Given this list of marker genes CDC20B, CDC20, PLK1, FZR1, CDK2, here is a description of the gene set: Any process that modulates the frequency, rate or extent of anaphase-promoting complex-dependent catabolic process. species: Homo sapiens Human Gene Set: GOBP_REGULATION_OF_ANAPHASE_PROMOTING_COMPLEX_DEPENDENT_CATABOLIC_PROCESS